The following is a description of a gene set: Mouse Gene Set: MIKKELSEN_NPC_ICP_WITH_H3K4ME3 species: Mus musculus Genes with intermediate-CpG-density promoters (ICP) bearing histone H3 trimethylation mark at K4 (H3K4me3) in neural progenitor cells (NPC). from publication Mikkelsen TS, Ku M, Jaffe DB, Issac B, Lieberman E, Giannoukos G, Alvarez P, Brockman W, Kim TK, Koche RP, Lee W, Mendenhall E, O'Donovan A, Presser A, Russ C, Xie X, Meissner A, Wernig M, Jaenisch R, Nusbaum C, Lander ES, Bernstein BE (PMID 17603471) We report the application of single-molecule-based sequencing technology for high-throughput profiling of histone modifications in mammalian cells. By obtaining over four billion bases of sequence from chromatin immunoprecipitated DNA, we generated genome-wide chromatin-state maps of mouse embryonic stem cells, neural progenitor cells and embryonic fibroblasts. We find that lysine 4 and lysine 27 trimethylation effectively discriminates genes that are expressed, poised for expression, or stably repressed, and therefore reflect cell state and lineage potential. Lysine 36 trimethylation marks primary coding and non-coding transcripts, facilitating gene annotation. Trimethylation of lysine 9 and lysine 20 is detected at satellite, telomeric and active long-terminal repeats, and can spread into proximal unique sequences. Lysine 4 and lysine 9 trimethylation marks imprinting control regions. Finally, we show that chromatin state can be read in an allele-specific manner by using single nucleotide polymorphisms. This study provides a framework for the application of comprehensive chromatin profiling towards characterization of diverse mammalian cell populations., and this is the list of marker genes: Kctd12b, Nudt22, Zfp870, D6Wsu163e, Med24, Zfp35, Prim1, Nop10, Zfp260, Zmat5 (zinc finger, matrin type 5), Acsbg1, Rp2, Slc7a11, B3galt2, Ank2, Cntn6, Stc1, Atg4a, Cox6a2, Zfp958, Zfp40, Rpl19, Hmmr, Cnpy4, Meak7, Atp6v1g2, Spred3, Frrs1, Car3, Dnajc4, Akr1b10, Lix1, Trappc13, Lrrn3, Abca8b, Ikzf2, Tmem198b, Mapk10, Cwf19l2, Tgfb3, Tmem256, Klhl5, Rhoj, Ypel4, Col1a1 (collagen, type I, alpha 1), Agpat4, Angpt2, Cald1 (NCBI Gene Id 73913), Bpgm, Aox1, Camk1, Stoml1, Dgkb, Zfp276, Prpf31, Drc3, Ccdc28b, Syt3, Ifit2, Tmem69 (transmembrane protein 69), Tspan11, Ak1, Ly96, Smug1, Zfp239, Pbx1, Etfbkmt, Zfp82, Pcdh9, Kcnj2, Slitrk6, Pcyt1b, Aldoc, Pml, Cntnap1, Zfp354b, Neil1, Sap30bp, Cdh10 (NCBI Gene Id 78694), Decr2, Gosr1, Inha, Fbxw7, Ptn, Sox5, Ctnnd1, Nckap5, Fbp2, Pcdhb2, Grm3, Prrc2a, Nol8, Irgm1, Cd44 (CD44 antigen), Polr2k, Lin52, Pde1c, Ech1, Akr1e1, Lamb2 (NCBI Gene Id 270417), Iftap, Zfp646, Atp5mc1, Alkbh8, Mrpl35, Slc12a6, Actn3, Emp1 (NCBI Gene Id 13730), Megf10, Fis1, Syt1, Kdm6b, Ppargc1a, Trak1, Tomm40l, Cdkn2c, Sfxn3, Rpl10, Golph3l, Mospd1, Tmem35a, Ccdc93, Adal, Ifitm2, Usp49, Gtf2h4, Fkbp14, Etv1, Zkscan5, Mpi, Kif14, Rapgef3, Flad1, Gemin6, Zfp182, Ccdc77, Mrgpre, Mmachc, Lysmd1, Rbbp9, Washc3, Rbm41, Supt7l, Akap7, Tut1, Zfp54, Mbnl2, Clic1, Actr6, Dclre1a, Ghdc, Slc26a7, Fbxo16, Hmg20a, Lpar4, Pabir2, Zfp87, Ehbp1 (EH domain binding protein 1), Ttc23, Zfp85, Cstpp1 (NCBI Gene Id 99024), Slc38a7 (solute carrier family 38, member 7), Timm21, Recql5, Vgll4, Rufy3, Wdr83os, Fastkd2, Zfp454, Tpcn2 (NCBI Gene Id 233979), Tctn2, Hdac6, Pde1a, Phkg2, Dynlt3, Dnali1, Cdhr4, Scnm1, Tnfaip6, Smarcal1 (SWI/SNF related matrix associated, actin dependent regulator of chromatin, subfamily a-like 1), Hspa1l, Nosip, Rcor2, Adamts4, Zeb2, Cd274, Spsb3, Apool, Wdcp, Lsg1 (large 60S subunit nuclear export GTPase 1), Zfp608, Zfp759, Blzf1, Cpt1c, Gpx8, Loxl3, Itm2a, Zc4h2, Ppp2r3c, Lrrtm2, Mcts1, Rbms2 (NCBI Gene Id 67173), Pycr1, Cpeb4, Ttll9, Pafah2, Axl, Aadat, Asb7, Cbln3, Frmd4a, Dnajc12, Zfp108, Mettl15, Rab13, Synj2, Cavin2, Zfp788, Tsnaxip1, Hdac9, Asb15, Dennd2b, Lpar6, Clec2d (NCBI Gene Id 93694), Gpm6a, Dync2li1, Gstm7, Plat, Pramel12, Tpp1, Ctso, Pter, Hspb6, Gab3, Pbxip1, Gng2, Dpp7, Fastkd1, Tcn2, Rfx5 (NCBI Gene Id 53970), Chrnb4, Atxn7l1, Fundc2, Dynlrb2, Tmem14a, Vps50, Armh4, Grn, Gcdh, Aloxe3, Sipa1, Lrp1, Gale, Vcam1, Srgap3, Trappc14, Bcl2l2, Tmem67, Mpv17, Apobec3, Sumf2, Zfp940, Tlk2, Brsk1, Wdr12, Trmt10b, Fas, Rin2, Lrrc4b, Mdh1b, Sspn, Fam3a, Tceal8, Abca9, Zfp317, Zfp871, Ccdc39 (NCBI Gene Id 99728), Nqo1, Ccdc141, Zfp84, Fundc1, Fam111a, Ndp, Ppp2r5c, Mt3, Tcaf1, Zfyve26, Fam13a, Gabrg1, Dclre1c, Zfp418, Gper1, Zfp874a, Sema3a, Katnal2, Mpst, 4833420G17Rik, Nicn1, Kctd20, Grik5, Zik1, Flrt3, Vps41, Wbp1l, Syn3, Scrg1, Extl1, Coro1a (coronin, actin binding protein 1A), Lrrtm3, Mtcl3, Zranb3, Creb5, Zfp93, Entpd1, Dtna, Zfp953 (NCBI Gene Id 629016), Pld1, Zfp109, Wdr38, Chac2, Fam222b, Zc3hc1, Hyal1, 2810408A11Rik, Lima1, Pus3, Pde4b, Tlr2, Rttn, Serpini1, H1f6, Zbtb18 (NCBI Gene Id 30928), Adcy6, Zfp27, Nme7, Lysmd4, G0s2, BC025920, Hsd17b11, Adhfe1, Riok2, Bmerb1, Nudt13, Kcnd2, Rbms3, Cc2d2a, Bbs1, B230217C12Rik, AI429214, Entrep3, Tmem100, Txlnb, Chm, Zfp952, Angpt1, Atp13a4, Tbc1d22b, Plin2, P2rx7, Zswim2 (NCBI Gene Id 71861), Osgepl1, Fkbp7, Cyb5r2, Osbpl7, Adamts6, Nrxn1, Slc37a4, Cd99l2, Mgst1, Dnai3, Zfp595, Ddr2, Erich6, Dnase1l1, Alg3, Lrrc4c, Bak1, Gmppa (NCBI Gene Id 69080), Slc15a2, Sat2, Mrtfb, Ctns, Prr11, Tkfc, Rbm4, Klc4, Cfap52, S100b, Sh3bgrl, Adamts12, Nsun6, Rai14, Acy1, Pold4, Ift56, Serinc4, Bche, Idnk, Ncan (NCBI Gene Id 270055), Pclaf, Arhgap18, Arhgef9, Lars1, Rdh11, Srpk2, Rem2, Exoc4, A2m, Slitrk1, Gpr183, Tfpt, Dglucy, Kcna4, Fndc11 (fibronectin type III domain containing 11), Zmynd8, Eola1, Ints9, Csrnp3, Pank1 (pantothenate kinase 1), Plpp7, Col4a5, Bivm, Igbp1, Clcn5, Nif3l1, Dlg4, Capn1, Ifi44l, Pcdhb5, Tmem242, Smim26 (small integral membrane protein 26), Zswim9, Tjp3, Nmral1, Pcdhb16, Wdr24, Atosa, A430033K04Rik, Dusp19, Rftn2, Rad51b, Nol4, Gap43, Gstm1, Tcim, Sparc, Nav3, Zfp112, Hras (Harvey rat sarcoma virus oncogene), Add3, Tbkbp1, Frg2f1, Thbs3, Sparcl1, Rad54l, Ctu1, Prcp, Lipa, Mterf2, Ftsj1, Zfp763, Tor1aip2, Trim46, Nxpe4, Trim16, Slc9a9, Susd4, Abcd2